The following is a description of a gene set: species: Homo sapiens Human Gene Set: GGGCATT_MIR365 Genes having at least one occurence of the motif GGGCATT in their 3' untranslated region. The motif represents putative target (that is, seed match) of human mature miRNA hsa-miR-365 (v7.1 miRBase)., and this is the list of marker genes: REV3L, KALRN, BMP1, MAP2K7, PHF12, LDB1, HIPK1, ANKRD28, HHIP, PAX6, SESTD1, ZNF644, USP48, BRD10, MAPK1IP1L, CSK (NCBI Gene Id 1445), LIN7C, RAPGEF4, SRGAP3, KMT2E, ESRRA, YWHAH, COL7A1, HDAC9, ZNRF1, TLL2, UBP1, TP53INP2, ARHGAP12, PLCB4, WDR37, ETS1, RAB22A, DLX3, JADE2, LAMP2, MYLK, ADM, ANKS1A, ETV1, ADD3, HDAC4, RNF152, AMMECR1, FMN2, CREB5, KLK15, SATB2, SNTB2, SLC8A2, ENTPD7, ARRB2 (arrestin beta 2), DTNA, SIX4, FAM91A1, ADAMTS6, ARRDC2, RUSF1 (NCBI Gene Id 64755), SGK3, RBM12, G3BP2, SNRK, FNDC3B, TMOD3, AKT3, PKD2L2, SRGAP1, USP33, HMGCR, SOCS5, VGLL4, SSH2, GALNT4, UBAC2, NUFIP2, RICTOR, ACVR1, PCNP, PTGDR, ANKRD17, API5, EFEMP1, TRHDE, PRDM1, RAB1B, MYLIP, GRAMD1C, SINHCAF, PAX2, SGK1, NR3C2, KCNH2, BCL11B, YTHDF2, NR4A2, SYNJ1, ARK2N, EIF4E3, ARMCX3, ING3, DCUN1D5, ANKRD11, MAU2, PLEKHA7, TIAM2, ST8SIA4, ARRDC3, PPP5C